The following is a description of a gene set: Mouse Gene Set: GOBP_MITOTIC_CYTOKINETIC_PROCESS species: Mus musculus Any cytokinetic process that is involved in mitotic cell cycle., and this is the list of marker genes: Cntrob, Vps4b, Iqgap3, Vps4a, Chmp3, Iqgap2, Exoc7, Cep55, Stx2, Pdcd6ip, Kif20b, Rhoa, Chmp2a, Aurkb, Rab11fip3 (NCBI Gene Id 353068), Ist1, Arf1, Zfyve19, Chmp7, Klhdc8b, Chmp1b2, Chmp2b, Ect2, Mitd1, Rab11a, Iqgap1 (IQ motif containing GTPase activating protein 1), Spart, Mtmr4, Chmp5, Kif20a, Chmp1a, Arf6 (ADP-ribosylation factor 6), Chmp6, Nup62, Chmp4c, Chmp4b, Chmp1b